Given this list of marker genes NT5C2 (5'-nucleotidase, cytosolic II), HPRT1, GDA, ADA, PRTFDC1, NT5C, AMPD3, PNP, XDH (NCBI Gene Id 7498), DPYS, NT5C1A, UPP1, NT5E, UPB1, DPYD, UPP2, here is a description of the gene set: studied in species Homo sapiens The chemical reactions and pathways resulting in the breakdown of a ribonucleoside monophosphate, a compound consisting of a nucleobase linked to a ribose sugar esterified with phosphate on the sugar. Human Gene Set: GOBP_RIBONUCLEOSIDE_MONOPHOSPHATE_CATABOLIC_PROCESS